The following is a description of a gene set: from publication Chen Y, Wang X (PMID 31504780) studied in species Mus musculus Mouse Gene Set: MIR_6958_3P Genes predicted to be targets of miRBase v22 microRNA mmu_miR_6958_3p in miRDB v6.0 with MirTarget v4 prediction scores > 80 (high confidence targets)., and this is the list of marker genes: Nrk, Rapgef2, Npepps (NCBI Gene Id 97764), Cfdp1, Jarid2, Sgcg, Tubgcp5, Afg3l2, Htr2c, Ephx2, Supt7l, Dcc, Neurl1b, Suclg1, Pitpnm3, Hlf, Ankfy1, Gpd1l, Luc7l3, Fnbp1l, Prex1, Nptn, Ppfibp2, Kirrel3, Il15ra, Rassf3, Rexo4, Dusp16, Homer1, Kank2, Bcl9, Cop1, Acnat1, Drg1, Dlg2, Nlk, Tiam1, Fbn2, Zfp706, Kdm3a, Nkd2, Rhoa, Adgrg5, Prss8, Ptbp1, Slc26a9, Lair1, Ints2, Arhgef6, Rbm18, Tanc2, Scn1a, Rprd1b, Mtdh, Elovl5, Chd2, Il17rd, Eya4 (EYA transcriptional coactivator and phosphatase 4), Bmf, Acvr2b (activin receptor IIB), Ppp1cb, Scml4 (NCBI Gene Id 268297), Arc, Spsb1, Cdk6, Fos, B3galt5, St3gal5, Yars1, Plagl2, Slc9a5, Kif6, Kif26b, Rbpj, Arhgef26, Mast4, Rskr, Nfya, Spag16, Prkci, Dennd2b, Ppm1a, Smad1, Sin3b, Traf3, Nipal4, Stx3, Epb41l5, Inpp5a, Lrp8, Cnot9, Rbsn (NCBI Gene Id 78287), Urm1, Il7 (interleukin 7), Ppfia1, Poll, Sohlh1, Napepld, Vwa2, Enc1, Prox1, Unk, Pik3ca, Ttl, Slc6a8, Zfp352, Col19a1, Ppp4r4, Pcsk9 (NCBI Gene Id 230573), Ly6h, Ppp1r15b, Cyfip2 (NCBI Gene Id 76884), Pot1b, Tfap2a, Mycbp2, Pmepa1, Icam1 (NCBI Gene Id 235038), Dusp10, Galnt16